Given this list of marker genes Abcb11, Tmem144, Slc23a1, Mfsd4b5, Slc5a9, Slc2a5, Slc2a6, Slc5a11, Slc2a9, Aqp7, Slc2a10, Slc5a1, Slc5a2, Slc5a4a, Slc45a4 (solute carrier family 45, member 4), Gm5134, Slc23a2, Slc2a4, Slc5a3, Slc50a1, Slc45a1, Slc45a2, Aqp9, Slc2a8, Slc2a2, Slc2a12, Slc2a3 (solute carrier family 2 (facilitated glucose transporter), member 3), Slc2a7, Aqp3, Slc5a4b, Aqp2, Slc45a3 (solute carrier family 45, member 3), Aqp1, Aqp11, Slc5a10, Slc2a1, here is a description of the gene set: Enables the transfer of carbohydrate from one side of a membrane to the other. Mouse Gene Set: GOMF_CARBOHYDRATE_TRANSMEMBRANE_TRANSPORTER_ACTIVITY species: Mus musculus